The following is a description of a gene set: In the present study we used Affymetrix oligonucleotide microarrays to produce gene transcription profiles for the major leukocyte types in humans. This comprehensive dataset enabled us to not only establish which genes were expressed in each leukocyte type, but also which genes were expressed in each subset after activation. The used of a comprehensive dataset of gene profiles from all the major human leukocyte subsets enabled a novel and powerful means for identification of genes associated with single leukocyte subsets, or different immune paradigms. Genes up-regulated in comparison of untreated dendritic cells (DC) versus DCs treated with LPS (TLR4 agonist) at 48 h. studied in species Homo sapiens Human Gene Set: GSE3982_CTRL_VS_LPS_48H_DC_UP from publication Jeffrey KL, Brummer T, Rolph MS, Liu SM, Callejas NA, Grumont RJ, Gillieron C, Mackay F, Grey S, Camps M, Rommel C, Gerondakis SD, Mackay CR (PMID 16474395), and this is the list of marker genes: TTC3, AMDHD2, GSTT1, CLEC10A, CORO1C, SNX13, FHL2, MIPEP, BTBD18, TGFBR3, CKB, CD36, DAB2, CPPED1, SEPTIN2, QPCTL, FZD2, P3H2, VLDLR, PTK2 (protein tyrosine kinase 2), SYNJ2, NDUFA4L2, MYCL, RRS1 (NCBI Gene Id 90810), REX1BD, SYNRG, RNF125, CHP1, TNFSF13, ZNF185, CHN2, CTSC, MAGOHB, HSD17B2, CEBPD, CENPF, RER1, RAB38, ITGB5, ESD, CD1C, MEF2C, CTDSPL, PREPL, CWC25, DNASE2B, FUT2, HMGN5, TAS2R13, MATK, IPCEF1, HLA-DPB1, NTM, APH1B, MS4A6A, AHCY, PLEKHS1, HDAC9 (histone deacetylase 9), HAMP, UCHL3, DNAJB1, TBC1D2, CYP2C18, RWDD2A, SLC29A2, MAPK1, SLC16A5, ZNF710, UCHL1, TAL1 (TAL bHLH transcription factor 1, erythroid differentiation factor), SPTLC3, GLE1, FBN2, FN3KRP, RGSL1, GPD1, RAD51AP1, HPCAL1, KDM7A, SORL1, FCMR, OR2F1, ITPKB, SEC23B, ITGB1BP2, KCTD15, OSBPL1A, IFNAR2, FAR2, CCNH, OPN3, ROCK2, CLIP2, CHRM4, PAK6, WDFY3, XK, CCDC86, NACC2, AZU1, BRD3, PSG5, FCER1A, PHF2, C1orf115, ZC2HC1A, RNF44, DNAJC10, ZNF223, ABCB4, UBXN8, WARS2, ADGRL2, PTBP1, ATP9A, MAGEB4, GLO1, EEF2, METTL2B, SNED1, ZMYND11, SLC18A2, PODXL, PGAM2, DOC2B, CD52, PHKG1, PRM1, HLA-F-AS1, BRMS1, MYF6, ARHGEF6, CD1B, MERTK, UBQLN3, CALU, THSD4, SYNJ2BP, PLCXD1, CPQ, CHCHD7, NCAPH (NCBI Gene Id 679), PLBD1, CMC4, ARL4C, PBK, LILRA2, CAPZB, ALDH3A1, OR5I1, ATAD2, CCDC92, NNT, WDR12, ALDH7A1 (aldehyde dehydrogenase 7 family member A1), TPP2, MTCL1, GDF9, JRKL, TUBA3D, CLOCK, THYN1, PLA2G15, IFNA21, NMB, GPER1, CORO2A, TFF1, SLC22A5, RBMS2 (RNA binding motif single stranded interacting protein 2), EIF2B1 (NCBI Gene Id 1967), PSG2, PER3, PRDX3, ADORA2B, DLGAP5, OR2H1, BRCC3, HNRNPAB, CUL4A, CAMTA1, H3C12 (H3 clustered histone 12), MTMR8, PAPSS1, SCIN, TNKS, DDX31, POLR1G, LEPROTL1, F13A1, VCL, FYN, ZNF706, CD300A, UBAP2L, CPNE3, RALGPS1, ME3, GTF3C5, RNH1